The following is a description of a gene set: from publication Doronin K, Flatt JW, Di Paolo NC, Khare R, Kalyuzhniy O, Acchione M, Sumida JP, Ohto U, Shimizu T, Akashi-Takamura S, Miyake K, MacDonald JW, Bammler TK, Beyer RP, Farin FM, Stewart PL, Shayakhmetov DM (PMID 23019612) Human Gene Set: GSE36078_WT_VS_IL1R_KO_LUNG_DC_AFTER_AD5_T425A_HEXON_INF_DN Genes down-regulated in Lung dendritic cell from Ad5 T424A hexon infection wildtype mice versus Lung dendritic cell from Ad5 T424A hexon inf IL-1R mice. species: Homo sapiens Discrimination between self vs. non-self and adequate response to infection and tissue damage are fundamental functions of the immune system. The rapid and global spread of known and emerging viruses is a testament that the timely detection of viral pathogens that reproduce within host cells, presents a formidable challenge to the immune system. To gain access to a proper reproductive niche, many pathogens travel via the host vasculature and therefore become exposed to humoral factors of the innate immune system. Although a cascade of coagulation factors plays a fundamental role in host defense for “living fossils” such as horseshoe crabs (Xiphosurida spp), the role of the coagulation system in activation of innate responses to pathogens in higher organisms remains unclear. When human type C adenovirus (HAdv) enters the circulation, 240 copies of coagulation factor X (FX) bind to the virus particle with picomolar affinity. Here, using molecular dynamics flexible fitting (MDFF) and high resolution cryo-electron microscopy (cryo-EM), we defined the interface between the HAdv5 hexon protein and FX at pseudo-atomic level. Based on this structural data, we introduced a single amino acid substitution, T424A, in the hexon that completely abrogated FX interaction with the virus. In vivo genome-wide transcriptional profiling revealed that FX-binding-ablated virus failed to activate a distinct network of the early response genes, whose expression depends on transcription factor NFKB1. Deconvolution of the signaling network responsible for early gene activation showed that the FX-HAdv complex triggers MyD88/TRIF/TRAF6 signaling upon activation of toll-like receptor 4 (TLR4) that serves as a principal sensor of FX-virus complex in vivo. Our study implicates host factor “decoration” of the virus as a mechanism to trigger innate immune sensor that respond to a misplacement of coagulation FX from the blood into intracellular macrophage compartments upon virus entry into the cell. Our results further the mounting evidence of evolutionary conservation between the coagulation system and innate immunity., and this is the list of marker genes: PGC, TP53INP1, CDC42BPA, FARS2, SNHG11, HSBP1, RFXANK, PLD4, CNPY2, TMEM268, VCP, C2orf88, SGMS2, STING1, ZFP36L2, ZFAND1, BBS2, CNP, VCPIP1, CAMSAP2, GRHL1, AICDA, CYP4V2, RAB10, PPARA, DENND4C, DIDO1, ZBTB18, MYPN, WBP1, IFFO2, KDM5B, MTMR10, TNIP1, DOK1 (docking protein 1), MOV10, PEX2, GPR153, FBXO11, MX1, DISP2, ARHGEF10, CCDC191, RPL19, RHOH (ras homolog family member H), C12orf57, IQCB1, ZCCHC12, CSNK1G2, EHD3, ARID5A, IRF2BPL, COPRS, CHRNG, HS3ST4, THYN1, CPLANE1, IL17RD, TNC, TTC3, MAPK11, IRF2BP2, FHL3, ZSCAN12, AFTPH, LRIG1, DZIP1, RCL1, OASL, BORCS6, LUZP1, C3orf33, MTOR, HHAT, TLR1, PTPRN2, BANF2, GLRX5, ADK (NCBI Gene Id 132), NR4A1, CCDC68, RSAD2, SSBP1 (NCBI Gene Id 6742), PCTP, NEU3, AHRR, NTPCR, PATJ, TSACC, CCR4, TRIO, PCCA, TMEM241, USP18, ANKRD13B, GTDC1, GRN, SLC9A9, CARD14, GPR183, CAMK2D, SLPI, IDUA, CEP43, IRGM, HS6ST1, HSH2D, LRRC26, RPL35, ATG10, DLG3, CDC40, L3MBTL3, INPP5F, CEP41, CARM1, CUL9, AHI1, PRMT3, CCDC137, ARHGEF11, DAG1, PECAM1, CCDC125, CDKL4, BMI1, GLIS3, PAIP2, NXPE3, ITGA7, DNAH8, CORO2B, SELENOW (NCBI Gene Id 6415), RTP4, IFIT1B, RPS15A, TPH1, CELA1, TMEM86A, P2RX4, GZF1, CD83, TMEM269, UBE3A, CD320, TBC1D5, WDR11, AGL, IFI44, TRAPPC6A (trafficking protein particle complex subunit 6A), PRNP, NUDT7, JDP2, MANBA, RPS4X, TTLL12, UQCC3, TIMM17B, CPA2, STAT1, RPL24, TESC, ARL3, HSDL2, XPC, PPTC7, C1orf216, MACROD1, B2M (beta-2-microglobulin), SYCN, MAN2B2, KIF13A, MPPE1, LAMP1, THOC5, ANKZF1, CCDC171, ITPR2, CELA3B, FARSB, NFE2L2 (NCBI Gene Id 4780), MBP, BCL11B, TLE3, AMZ2, DLX2, EXT2 (exostosin glycosyltransferase 2), CYLD, TLR3, DUSP9, SPAG4, FKBP9 (NCBI Gene Id 90212), ACVR1B, ENDOD1, PHF21A, MFSD3, ABTB3, TMEM38B, FCER2